The following is a description of a gene set: Human Gene Set: GSE15733_BM_VS_SPLEEN_MEMORY_CD4_TCELL_UP from publication Tokoyoda K, Zehentmeier S, Hegazy AN, Albrecht I, Grün JR, Löhning M, Radbruch A (PMID 19427242) CD4+ T lymphocytes are key to immunological memory, but little is known about the lifestyle of memory CD4+ T lymphocytes. We showed that in the memory phase of specific immune responses to antigens, most of the memory CD4+ T lymphocytes relocated into the bone marrow (BM) within 3-8 weeks after their generation, a process involving integrin a2. Antigen-specific memory CD4+ T lymphocytes expressed Ly-6C to a high degree, unlike most splenic CD44hiCD62L- CD4+ T lymphocytes. In adult mice, more than 80% of Ly-6Chi CD44hiCD62L- memory CD4+ T lymphocytes were in the BM. In the BM, they are located next to IL-7-expressing VCAM-1+ stroma cells, and were in a resting state. Upon challenge with antigen, they rapidly expressed cytokines and CD154 and induced the production of high-affinity antibodies, indicating their functional activity in vivo and marking them as professional memory T helper cells species: Homo sapiens Genes up-regulated in comparison of CD4 T cells from bone marrow versus those from spleen., and this is the list of marker genes: PRTN3, HACD1, MSRB3, ROGDI, ICAM1, PEAK1, ZNF264, F5, FBXO36, A4GNT, APLP2, GRIN2B, ZNF512, FMO2, PCDHB7, C1QL1, ARHGAP36, ANKRD24, ARSB, KLRC1, GAL3ST2, CPPED1, GPR12, ALOX5, SSTR2, SLCO4C1, CORO2A, ZBTB16 (NCBI Gene Id 8070), BUB1B (BUB1 mitotic checkpoint serine/threonine kinase B), KLRD1, BOLL, PDZD11, PRKD3, HP, MGAT4B, MMP9, ADGRG5, S100A8, MUC16, FPR2, SYK, PIF1 (NCBI Gene Id 89987), SLC13A5, AQP9, ADAMTS4, LMO2, TNS3, CISH, AQP8, CD27-AS1, HSD17B3, SCEL, LTB4R, PYGL, SELENOV, RASEF, SLC10A2, FOXN4, LRRIQ4, IFNGR1, SRGAP3, NEDD4, ADAMTS8, ANXA1, FAM171B, BMP5, NKG7, SLFN12 (NCBI Gene Id 55106), SLC41A2, CPA3, KCTD7, MAPK15, STOM, DUS4L, PLS1, ATOX1, RCBTB2, SPMAP2, FAM181A, ASF1B, FHOD3 (formin homology 2 domain containing 3), FGFRL1, CLCN5, CTSG, LPL, KALRN, DDAH1, CSRP2, MPEG1, CLEC14A, CHRNA3, SLC27A5, PHOX2B, FCER1G, EPB41L4A, CHSY1, COL27A1, CTSW, DYNC2I1, SCN9A, GDA, CADM4, BARD1, RAB31, PPFIBP2, IFNG, MISFA, ARG2, APOBR, HMOX1, LYN, SMYD1, BEND6, ALOX5AP, TUBD1, LTF, DUSP6, FGFR4, SEMA6C, TF, BAD, CXCR6, IL1RL1, TYROBP, CDSN, PIK3AP1, TNFAIP3, CRB3, HRH3, CERK, SFTPB, CXCL14, CAMP, GNG4, TTLL13, BHLHE40, PADI2 (NCBI Gene Id 11240), CD177, TRIM7, BBS9, ANKRD13B, CREB3L3, HMX3, MGST1, FASLG, CLEC7A, E2F1, F8, FRK, UBALD2, MPO (NCBI Gene Id 4353), MACROH2A2, F8A1, KLRG1, POU3F3, DEPP1, TMPRSS3, SORT1, SOX21, SERINC3, ATXN7L2, WDR35, MTSS2, SLCO2A1, COMMD5, CPEB1-AS1, GABRA3, MMP1, WIF1, LCE2B, EFEMP2, DRAM1, SEMA3F, IGF2BP3, PIM1, DSP, TM6SF1, APOE, OPRK1, PALS1, GBP7, RNF130, KCTD12, SMARCA1, CYBB, TTLL9, TMEM150B (NCBI Gene Id 284417), SLC4A10, LYST, KCNG4, CCRL2, STAC3, CCL24, GRM7, MXD1, SLCO1A2, CA2, PROM1, CFAP90, CRAT